Given this list of marker genes ADAMTS12 (ADAM metallopeptidase with thrombospondin type 1 motif 12), HPS1, ARHGAP23, TMPRSS3, MIB1, ANXA4, FAM135A, RNASE6, TMEM47, MSRA, IDH3G, TUBA3C, ENOX2, PHACTR4, BCL2L12, HSD17B4, PTPRE, SGK3, ARHGAP18, LDAF1, ITPRIPL2, CHML, MORC1, MOSPD3, FADS1, GTF2IRD1, MTCL2, ACACA, UBFD1, CDCA2, RSPH3, SPP1 (NCBI Gene Id 6696), CBX6, LRFN4, DTNBP1, GCSH, LIX1L, VAV3, UXS1 (UDP-glucuronate decarboxylase 1), NFAM1, TXN, INCENP, BOD1, B3GALT6, TRIQK, TEDC2, E2F8, MGST3, TBC1D4, COL16A1, CCDC120, EIF2AK4, PGM2, GPRASP2, INTS6L, KIF18A, ST14, ADAM22, TMBIM4, SNHG32, CFAP68, HLA-DRB1, AHNAK2, B3GLCT, SANBR, DHRS4, TCAF1, KIFAP3, PIGN, CITED2, SLC25A13, TELO2, NCAPG, SLF2, TOM1L1, TIE1, STAU2, GALNTL5 (NCBI Gene Id 168391), ZKSCAN1, VAT1, SHMT1, MBD6, COL4A1, CDK2, IPO11, TSPAN4, AIFM1, TRIM47, SIRT4, ACSL3, DTYMK, OGFRL1, CPNE3, HSPA12B, ZC4H2, FGD5, TNFRSF1A, EBI3, CLDN12, RPS6KA5, LIPT2, GOT2, SNHG7, ATG4C (autophagy related 4C cysteine peptidase), DHRS3, FLYWCH1, IFTAP, MTFR1, EFCAB7, CC2D2A, PPM1L, RELL1, RPS6KA6, RIPOR1, SLC5A9, GLOD4, TMEM106C, FLT3, CLEC1A, KLHDC10, CUL1, CREB3L2, CCNF, YPEL2, MAP1LC3A, C6orf132, MAPK14, LPCAT1, PIBF1, EHMT2, PDCD7, CNBP, SLC2A3, NTPCR, CSF2RA, TICRR, ADAM9, PRDX4, COASY, TACC3, TBC1D32 (NCBI Gene Id 387102), UBE3D, TUBB6, MYO1D, C9orf85 (NCBI Gene Id 138241), RASGEF1B, TOLLIP, SRRT, PGGHG, CCDC181, TRAK1, VDAC3, LTBR, STAM, IQGAP3, TMT1A, MCM5, HK1, MOAP1, PTOV1, CLCN5 (chloride voltage-gated channel 5), HAGHL, OAS1, REV1, C11orf24, ARHGAP21, FH, SF3A1, KDM2B, CHEK2, MATN2, POLD1, IL7, HNRNPA0, BMP1, MTFR2, SKIC3, NUP62, C12orf75, PLEKHF1, MMGT1, ZMYND8, RAMP1, NDST1, SLC7A5, TMTC3, KCNQ5, MYLK, NFIC, AFF3, AURKA, HEXA, NBDY, GLCE, COQ4, LPIN2, CCDC34, CASP3, FAM217B (family with sequence similarity 217 member B), here is a description of the gene set: Each fraction of mouse hematopoietic cells was purified by cell sorting from bone marrow of 8-week-old C57BL/6 mice, and its gene expression was analyzed. Human Gene Set: GSE27786_LSK_VS_CD8_TCELL_UP Genes up-regulatd in comparison of LSK versus CD8 T cells. from publication Konuma T, Nakamura S, Miyagi S, Negishi M, Chiba T, Oguro H, Yuan J, Mochizuki-Kashio M, Ichikawa H, Miyoshi H, Vidal M, Iwama A (PMID 21540074) studied in species Homo sapiens